Given this list of marker genes HADH, TRIM44, VAMP7 (vesicle associated membrane protein 7), TNRC6B, USP4, AKR1C1, KDR, USP10, DHX15, MPST, RERE, HRH1, CNOT1, PDHB, CYB5B, CD24, ATP5ME, EEF1A1, TMEM63A, PYGB, DDX27, MFSD10, PRKAG1, RPS27, CTSA, DDB1, TRIM33, FTH1, ACVR1B, B2M, CFB, DDR1, TERF2IP, PDXDC1, IVNS1ABP, AHCYL1, NFKB1, HMGN4, CHIT1, UBE4B, GAS6, RPL38, SARS1, RPL36A, IMPA2, LYRM1, NDUFS6, GNAI2 (G protein subunit alpha i2), NUDC, RSRP1, DUSP3, CSNK1D, SEL1L3 (NCBI Gene Id 23231), COASY, AARS1, XRCC5 (NCBI Gene Id 7520), ZBED1, HIPK1, PPID, SURF1 (SURF1 cytochrome c oxidase assembly factor), PROM1, ABCD3, ARF4, DNAJC7, NELFA, LAMP1, CRIPTO, H3-3A, RBL2, PRKCD, CUL4B, ADGRG1, CFTR, CDH1, LAGE3, CD44, BTN3A1, H3P37, SON, GPX2, TPR, RPL13, DRG1, NDUFB5, IDH3G, REG1B, PPP2R5A, MC1R, MARCHF6, FCGRT, PHLDB1, GOLGA4, POLR2K, PCK1, MGRN1, RAP1A (NCBI Gene Id 5906), SREK1, RRM1, CYP2A13 (NCBI Gene Id 95745), GSE1, WASHC2C, RPS13, WDR1, PIP5K1B, SLC35A3, BBLN, MRPL12, TMEM115, MRFAP1L1 (Morf4 family associated protein 1 like 1), CITED1, CBLB, SUMO4, ATP1A1, here is a description of the gene set: from publication Watanabe T, Komuro Y, Kiyomatsu T, Kanazawa T, Kazama Y, Tanaka J, Tanaka T, Yamamoto Y, Shirane M, Muto T, Nagawa H (PMID 16585155) Preoperative radiotherapy has been widely used to improve local control of disease and to improve survival in the treatment of rectal cancer. However, the response to radiotherapy differs among individual tumors. Our objective here was to identify a set of discriminating genes that can be used for characterization and prediction of response to radiotherapy in rectal cancer. Fifty-two rectal cancer patients who underwent preoperative radiotherapy were studied. Biopsy specimens were obtained from rectal cancer before preoperative radiotherapy. Response to radiotherapy was determined by histopathologic examination of surgically resected specimens and classified as responders or nonresponders. By determining gene expression profiles using human U95Av2 Gene Chip, we identified 33 novel discriminating genes of which the expression differed significantly between responders and nonresponders. Using this gene set, we were able to establish a new model to predict response to radiotherapy in rectal cancer with an accuracy of 82.4%. The list of discriminating genes included growth factor, apoptosis, cell proliferation, signal transduction, or cell adhesion-related genes. Among 33 discriminating genes, apoptosis inducers (lumican, thrombospondin 2, and galectin-1) showed higher expression in responders whereas apoptosis inhibitors (cyclophilin 40 and glutathione peroxidase) showed higher expression in nonresponders. The present study suggested the possibility that gene expression profiling may be useful in predicting response to radiotherapy to establish an individualized tailored therapy for rectal cancer. Global expression profiles of responders and nonresponders may provide insights into the development of novel therapeutic targets. Human Gene Set: WATANABE_RECTAL_CANCER_RADIOTHERAPY_RESPONSIVE_UP Genes up-regulated in rectal cancer patients resistant to radiotherapy (non-responders) relative to the sensitive ones (responders). studied in species Homo sapiens